Given this list of marker genes PDCL, TUBD1 (NCBI Gene Id 51174), POR, GPC3, CHSY1, TXNDC15, FGF9, SHH, PRRX1, CTNNA1, TTC23, TEDC1, ARMC9, KIF7, STK36, SKOR2, TEDC2, CIBAR1, SFRP1, GLI1, EVC, DYNC2H1, RAB34, ISL1, DHH, IHH, FOXA1 (forkhead box A1), IFT172, SCUBE1, INTU, GORAB, DLG5, SMO, ULK3, DCDC2, UCHL5, NDST1, GAS8, SHOX2, here is a description of the gene set: studied in species Homo sapiens Human Gene Set: GOBP_POSITIVE_REGULATION_OF_SMOOTHENED_SIGNALING_PATHWAY Any process that activates or increases the frequency, rate or extent of smoothened signaling.